Given this list of marker genes Akap14, Klhl5, Dzip1, Rgp1, Mapkap1 (mitogen-activated protein kinase associated protein 1), Ppp3r1, Pramel39-ps, Snap25, Rag1, Cnot7, Trappc6b (NCBI Gene Id 96981), Anapc15 (anaphase promoting complex C subunit 15), Taf3, Kat5, Pex2, Lig4, Pramel57, Psmf1, Usp47, Eif4g3, Fem1c, Ranbp10, Pold2, Kctd17 (potassium channel tetramerisation domain containing 17), Fbxl16, Taf4b, Dtnbp1, Ccz1, Taf8, Cdc23 (NCBI Gene Id 52563), Dcun1d4, Cnot8, Eif2b5, Msl3l2, Tsen2, Psmb6, Eif4g2, Rpp14 (NCBI Gene Id 67053), Lamtor5, Ddb1, Spsb4, Dcaf13, Ing5, Psmb4, Prkaca, Trmt10c, Borcs7, Siah1b, Dnaaf2, Kxd1, Atg3, Mon1b, Ube2d2a, Card9, Hspb8, Pramel53, Rbx1 (NCBI Gene Id 80401), Bloc1s4, Hps4, Fbxw5, Bard1, Dpm1, Klhl3, Klhdc1, Polrmt, Znfx1, Cdc20, Pigm, Psmd10, Polr1f, Psmd4, Ctnnb1 (catenin beta 1, NCBI Gene Id 12387), Otud6b, Atf2, Fbxl5, Prkag3, Rars1, Map3k7, Dars1, Leo1, Pdcd6, Ubr3, Gtf2h4, Pramel35, Pramel51 (NCBI Gene Id 100039315), Pramel37, Fbxo6, Bloc1s1, Tsen34, Mat1a, Dock1 (NCBI Gene Id 71571), Rnf19b, Rad23a, Bloc1s5, Wdr5, Tes3-ps, Rpp30 (NCBI Gene Id 54671), Brca1, Psmd2 (NCBI Gene Id 77434), Fbxl15, Fem1b, Ptges3, Camk2g, Supt7l, Mrgbp, Actb, Trappc1, Slx4, Kctd13, Mnat1, Elmo1, Oog2, Fbxo31, Supt3, Psmd1, Nccrp1, Bcl10, Ccdc61, Stk11, Pramel56, Fbxl4, Brd8dc, Mib2, Klhl38, Rnf144a, Med20, Wdr77, Pramel16, Med12, Arnt, Cbx2, Ube3d, Eloc (elongin C), Anapc11, Med27, Naa16, Eme2, Mir28a, Pole3, Kbtbd8, Klhl15 (NCBI Gene Id 76150), Dmac2, Lars1, Epc2, Rpp38, Adrm1, Rnf19a, Cdc16, Siah1a, Epc1, Tsc1, Abat, Syncrip, Prkab1, Ahr, Hsp90ab1, Asb11, Otulin, Cenpf, Asb2, Commd1, Clp1, Rtcb, Fbxw11, Fbxl17, Tarbp2 (NCBI Gene Id 21357), Trappc11, Klhl12, Sdf2, Snapin, Csnk2a2, Katna1, Klhl10, Sf3b5, Ptges3-ps, Prr5l, Pramel32, Tada2b, Gtf2a2, Cpeb3, Psmd11, Zswim4, Rbck1, Atxn7l3, Trappc2, Rnf31, Zfand2b, Xrcc6, Tada2a, Gid4, Taf9, Kat6b, Klhl13, Syvn1, Pramel18, Zfand2a, Ccnh, Gsk3a, Cntrl, Zyg11b, Nfkb2, Klhl6, Ankib1, Fbxo24, Med23, Bag2, Dcaf7, Ppp3cc, Lamtor4, Pramel17, Oog3, Msl3, Stx12, Fbxo7, Gsk3b, Polr1a, Ide, Psma2, Asb9, Dcaf8l, Fbxl18, Polr1e, Adrm1b, Rad23b, Klhl42, Trappc6a, Fbxo48 (NCBI Gene Id 319701), Polr2m, Usp14, Ube2c, Taf6, Msl1, Psmb8, Pcgf6, Vhl, Ube2b, Ect2, Hnrnpu (NCBI Gene Id 98724), Anapc2, Kctd5, Brd8, Qrsl1, Rnf7, Naa50, Eif2b4, Cul9, Fbxo17, Aip, Hsd17b10, Fbxl2, Pramel11, Cct4, Aurkaip1, Klhl41, Cand1 (NCBI Gene Id 76147), Med31, Mat2a, Hps5, Akt1s1, Dgki, Dcaf15, Atxn7, Ago4, Hps6, Wdr83os, Hsf1, Ankrd9, Tnfaip1, Prim1, Pramel15, Morf4l2, Mad2l2, Ciao3, Patl1, Med1, Cdc27, Fbxl14, Dtl, Arnt2, Ctr9, Pramel59, Ago1, Pramel38, Polr3f, Sf3b3, Dnajb2, Brca2, Naa38, Axin1 (axin 1), Trappc2b, Dcaf11, Pcgf2, Fbxl3, Keap1, Rnf40, Dpm3, Jade3, Psmc4, Ube2s, Pramel43, Prkacb, Ago3, Zswim8, Pramel50, Pramel44, Rmnd5b, Bmi1, Rnf168, Sel1l, Prim2, Fbxo8, Trpc4ap, Gtf2h1, Rad18, Psmd9, Oog1, Tbp, Camk2a (calcium/calmodulin-dependent protein kinase II alpha), Snap47, Spop (NCBI Gene Id 20747), Arih1, Amfr, Zer1, Rnf14, Psmd7, Ddb2, Eif4g1, Pggt1b, Anapc1, Klhl22, Fbxl21, Psma4, Tsn, Fam98c, Gtf2a1l, Msl2, Prkn, Actg1, Ciao2b, Socs7, Pef1, Gatc, Camk1g, Taf10, Med30, Pramel19, Dpm2, Dctn1, Anapc16, Dcaf6, Aimp2, Ercc2, Kctd10, Pop4, Prickle1, Klhl7, Psmc5 (protease (prosome, macropain) 26S subunit, ATPase 5), Ruvbl1, Psme2, Skp1, Prkra, Trappc5, Fzr1, Ecpas, Kansl2, Cep83 (NCBI Gene Id 77048), Itpr1, Apc2, Taf9b, Asb17, Dcaf5, Klhdc3, Gtf2e2, Elp6, Klhl21, Fbxw7, Pramel13, Cct7, Ube2v1, Cul3 (NCBI Gene Id 98674), Polr3k, Trappc12, Cdk7, Cul5, Bloc1s2, Cbx7, Prkar1a, Gpr37, Cnot4 (NCBI Gene Id 53621), Psmb10, Rap1a, Ddx1, Fbxo44, Sclt1, Ppp3r2, Ypel5, Gtf2b, Abtb1, Pramel20, Psma3, Prkx, Pola2, Ep400, Kansl1l, Borcs6, Psmc1, Polr3b, Psmb11, Sem1, Psme1, Trappc4, Anapc7, Psma8, Bloc1s3, Vcp, Klhl18, Rptor, Rbx1-ps, Kbtbd3 (NCBI Gene Id 69149), Actl6a, Ppp3cb, Tbpl1, Ubac1, Asb12, Armc8, Ubqln1, Dnajc9, Cdc26, Supt20, Camk2b, Cep170, Elp3, Prkaa1, Kctd2, Maea, Fbxl22, Ubr1 (ubiquitin protein ligase E3 component n-recognin 1), Psme3, Cul1, Fbxo2, Prkab2, Kbtbd2, Pramel6, Ube2a, Brd1, Wdtc1, Gan, Mkln1, Prkag2, Cul4a, Eprs1, Dclre1c, Psmb2, Polr2l, Pramel14, Polr2f, Tchp, Fbxo25, Tob1, Cnot6, Kat2a, Smurf2, Ubr2, Polr3e, Skic8, Spag1, Yeats2, Pop1, Samd11, Yeats4, Gid8, Klhl11, Megf8, Fbxo32, Rchy1, Pramel22, Klhl8 (kelch-like 8), Cdc20b, Klhl24 (NCBI Gene Id 98030), Crbn, Nfkb1, Pramel49, Zbtb8os (zinc finger and BTB domain containing 8 opposite strand, NCBI Gene Id 69599), Myzap, Pramel27, Pramel60, Psma1, Phf20l1, Ube2srt, Zfp36, Phc1, Tmem183a, Socs2, Polr1g, Fbxo15, Mcrs1, Pramel36, Polg2, Med18, Fbxo3, Cdkn1b, Taf5l, Ppp5c, Ivns1abp, Gm13040, Gtf2h3, Lrrc75a, Eif2b3, Polr2h (polymerase (RNA) II (DNA directed) polypeptide H), Sharpin, Cks2, Xrcc5, Bloc1s6, Axin2, Ambra1, Klhl35, Pomt1, Spsb3, Mus81, Card11, Hspa8, Anapc5, Tsnax, Ago2, Cul2, Klhl2, Psmb1, Ercc8, Polr2d, Fbxl20, Iars1, Aimp1, Lamtor3, Klhdc10, Rtraf, Hdac6, Psmc3, Kansl3, Pramel61, Enc1, Gtf2f1, Strada (NCBI Gene Id 77993), Prkaa2, Pcmtd1, Rad51c, Pramel40, Hps3, Fem1a, Gtf2h2, Bmal2, Dcaf12l2, Med7, Ccdc47, Ercc3, Phc3, Rpap3, Oog4, Trappc9, Pramex1, Med11, Taf4, Pold4, Cbx6, Ube3a, Klhdc2, Trrap, Fbxo27, Cdk8, Brpf1, Ncbp2, Ncbp3, Naa12, Samd7, Polr3a, Wdr18, Fnta, Med6, Med21, Ube4b, Ranbp9, Klhl30, Lamtor1, Cep128, Ncbp1, Nfkbia, Ctu1, Nedd4 (NCBI Gene Id 639396), Rpap1, Fbxo42, Pramel25, Rad51, Klhl28, Stip1, Anapc13, Rnf7l, Mars1, Dna2, Med17, Lztr1, Dnajb11, Sdf2l1, Ikbkg, Trappc10 (trafficking protein particle complex 10), Ubqln4, Dr1, Pigv, Csnk1a1, Xrcc4, Pole2, Klhl23, Cnot1, Rnaseh2a, Cop1, Fbxw8, Eif4a2, Polr1c, Mir27a, Naa15, Fbxl6, Fam98b, Dmap1, Rpl5, Pramel28, Pramel45, Topors, Dicer1, Pold3, Psmb9, Larp1, Psma5, Cct8, Paf1, Anapc10, Tuft1, Polr2a, Jade2, Eif4a1, Naa20, Spsb2, Cdc37, Trappc3, Klhl9, Kat6a, Tnks1bp1, Dcun1d5, Ccdc68, Rpp25, Psmd14 (proteasome (prosome, macropain) 26S subunit, non-ATPase, 14), Ahrr, Elp2, Pramel54, Dhx9 (NCBI Gene Id 98320), Cct3, Ric1, Meaf6, Trim21, Pramel30, Pramel34, Psmg2, Fam8a1, Arih2, Fbxl9, Kndc1, Sesn2, Rnf144b (ring finger protein 144B), Rnf8, Pcgf3, Csde1, Psme4, Mms19, Cnot2, Naa25, Gatb, Cnot10, Pramel46, Ogt (NCBI Gene Id 77137), Cacybp, Kat8, Usp25, Polr1h, Mtor, Rnf20, Racgap1, Fam98a, Elob, Naa30, Prkdc, Mlst8, Psmd8, Actbl2, Rnaseh2c, Hcfc1, Fbxw4, Zfp326, Phc2, Cbx8, Ccdc120, Psmc2, Wdr26, Ccnf, Prr5, Cct8l1, Cul7, Pramel41, Ing4, Pramel5, Ruvbl2, Rnf11, Pramel42, Actl6b, Tada3, Kat14, Ccin, Pcgf5, Smcr8, Cnot3, Anapc15-ps, Ccar2 (cell cycle activator and apoptosis regulator 2), Fbxl13, Naa11, Psmd13, Ring1, Elobl, Taf5 (TATA-box binding protein associated factor 5), Fbxl12, Stub1, Psmg1, Asb4, Eef1e1, Igf2bp1, Naa35, Fbxl7, Zswim5, Dda1, Ube2n, Fbxl19, Ybx1, Usp22, Rasgrp3, Pramel23, Morf4l1, Taf13, Klhl29, Pcgf1, Sgf29, Cct6a, Pde3b, Zzz3, Trappc13, Polg, Ciao1, Psma6, Klhl40, Plaa, Klhl25, Cks1b, Prorp, Appbp2, Kbtbd7, Vps72, Dcaf10, Bcl3, Spsb1, Pi4k2a, Trappc3l, Polr2g, Taf1, Glmn, Primpol, Fbh1, Gtf2f2, Ep300, Pola1, Cep89, Polr2b, Trappc8, Csnk2b, Pramel33, Ctnnbip1, Pramel29, Gtf2a1, Fbxo45, Ube2e1, Kbtbd12, Tsen54, Wdr41, Elp1, Pramel55, Gtf2e1, Traf2, Washc4, Brpf3, Trappc2l, Cep164, Skp2, Polr1d, Mon1a, Malt1, Uchl5, Slc38a9, Rpp21, Ipp, Amn1, Anapc4, Pole4, Klhl20, Rmnd5a, Med24, Polr2j, Mgrn1, Polr1b, Pramel31 (NCBI Gene Id 433779), Polr3d, Kat2b, Cdc73, Eny2, Ube4a, Eif4e1b, Prkar1b, Polr2i, Pnkp, Fbxo9, Taf2, Zyg11a, Med10, Trappc14, Taf7l, Eif2b1, Btrc, Cct2, Apc, Dcun1d2, Zswim6, C9orf72 (C9orf72, member of C9orf72-SMCR8 complex), Polr3c (polymerase (RNA) III (DNA directed) polypeptide C), Neurl2, Las1l (NCBI Gene Id 76130), Pramel47, Dcaf4, Eif4e, Elp5, Fbxo4, Psmd3, Nhej1, Babam2, Cct6b, Tti1, Det1, Brap, Csnk2a1, Kars1, Phf20, Cks1brt (NCBI Gene Id 633546), Pramel21, Hspb1, Drosha, Rictor, Naa10, Hps1, Elp4, Dcun1d1, Bag3, Taf12, Ciao2a, Taf6l, Mbtd1, Eif2b2, Dcaf12, Brcc3dc, Ing3, Klhl17, Slc10a2, Tcp1, Pih1d2, Ccnc, Nin, Cbx4, Odf2, Dcaf8, Ube2j2, Kbtbd6, Psmd5, Qars1, Psmd12, Pop7, Klhl1, Polr2e, Taf7, Pramel7, Psmd6, Acte1, Polr2k, Pramel26, Cnot6l, Rnf217, Pold1, Crcp, Cnot11, Pop5 (processing of precursor 5, ribonuclease P/MRP family (S. cerevisiae)), Bcor, Dact1, Lamtor2, Pramel24, Borcs5, Eif4e2, Ube2d1, Ube2v2, Dcaf1, Itch, Sesn3, Psmc6, Depdc5, Rpp25l, Ppp3ca, Polr2c, Pramel1, Washc1, Dcaf17, Paxx, Rmc1, Camk2d, Dgcr8, Tert, Borcs8, Tada1, Rnf2, Fbf1, Taf11, Rtf1, Pramel12, Pole, Cct5, Prkag1, AI597479, Fbxo39, Tcea1, Eif4e3, Kif23, Klhl4, Psmb5, Spopl, Daw1, Polr3g, Kansl1, Crebbp, Mbip (MAP3K12 binding inhibitory protein 1), Eme1, Gch1, Asb1, Prkar2b, Rnaseh2b, Kat7, Pramel48, Mat2b, Polr3h, Brcc3, Cblc, Rpp40, Gtf2h5, Prkar2a, Rev3l, Trim63, Txnl1, Traf7, Dyrk2 (NCBI Gene Id 69181), Psmb7, Dcaf12l1, Bmal1 (NCBI Gene Id 11865), Psma7, Cnot9, Cul4b, Jade1, Polr3gl, Fem1al, Dcun1d3, Psmb3, here is a description of the gene set: Mouse Gene Set: GOCC_INTRACELLULAR_PROTEIN_CONTAINING_COMPLEX A protein-containing complex located intracellularly. studied in species Mus musculus